The following is a description of a gene set: Mouse Gene Set: GOBP_REGULATION_OF_SYNAPTIC_ACTIVITY Any process that modulates the frequency, rate or extent of synaptic activity, the controlled release of neurotransmitters into the synaptic cleft and their subsequent detection by a postsynaptic cell. species: Mus musculus, and this is the list of marker genes: Mef2c, Sybu, Reln, Agrn, 2610042L04Rik